The following is a description of a gene set: studied in species Mus musculus Genes predicted to be targets of miRBase v22 microRNA mmu_miR_6967_3p in miRDB v6.0 with MirTarget v4 prediction scores > 80 (high confidence targets). from publication Chen Y, Wang X (PMID 31504780) Mouse Gene Set: MIR_6967_3P, and this is the list of marker genes: Prr3, Hycc2, Ythdc2, Slc35a2, Tbc1d23, Cebpb, Slc39a1, Tstd2, Nsmce4a, Mtx3, Fgfr1op2, Ccng2, Rras2, Gngt1, Ablim3, Vmn1r32, St3gal6, Fmnl1, Arsj, Rhbdf2, Afap1l1, Bend3, Mga, Fgd2, Ergic2, Tsr2, Cldn12, Marf1, Nprl3, Rbm4, Taf7, Mia2, Gtf2a1, Glrx, Glrx2, Trps1, Cd300a, B3galnt2, Atad2b, Qpct, Strn3, Sall4, Mpig6b, Psd2, Rpl27a, Ppp2r2a, Awat1, Satb1, Isg15, Fam118a, Prtg, Cbx6, Trabd2b, Dennd2d, Zcchc10 (NCBI Gene Id 67966), Rhox6, Rimoc1, Pigv, Sycp3, Zbtb41, Fundc1, Abtb3, Hopx, Rnf2, Klhl2, Mtch2, Snai2, Klri2, Ndfip2, Dgkk, Ifi44, Slc39a8, Ak8, Usp45, Gen1, Zfp36l1, Golga1, Larp4, Dab1, Tapt1, Ptgr3 (NCBI Gene Id 225791), Alg5, Slc25a39, Itga8, Crtap, Peli1, AA986860, Ddx3x, Klhl23, Sntb2, Sp4, Syce1l, Cfhr4, Arl5a, Pappa, Tmem41a, Hsd17b12, Ube2k, Cdc73, Ppp1r17, Gbe1, Fam149a, Mapk8, Ppat, Galk2, Lsm11 (NCBI Gene Id 72290), Fez2, Larp1, Tnfaip8, Hectd1, Tmem185b, Zfy1, Rcor3, Man1a2, Ppp3r1, Gpr85, Rbm3, Nxph1, Rap1gds1, Mmut (NCBI Gene Id 319389), Rhox9, Dnmt3b, Cdkn1b, Spdye4a, Asb5, Lamp3, Ovol1, Rbm27, Fgf11, Atg5 (autophagy related 5), Sertad2, Atp5mc3, Etv5, Nhs, Pias3, Cbfa2t2, Esrp2, Celf4, Nedd4, Actrt2, Lrrtm2, Ascl2, Dpy19l2 (dpy-19 like 2), Srsf6, Naa30 (NCBI Gene Id 75009), Ppp4r2, Prkar1a, Kpna1, Crebrf, Arel1, Sipa1l1, Otud7b (OTU domain containing 7B), Calr3, Zfp37, Proser1, Sh3rf3, Avl9, Onecut2, Ctxn3, Mesp1 (mesoderm posterior 1), Phf20l1, Zfp518a, 1700025G04Rik, Tbc1d4, Tmem117, Nab1, Mrc1, Pgk1, Stx7, Gabra1, Myo1g, Spata17, Camkk2, Hsdl2, Fmr1, Pou4f1, Tnrc6c, Rsbn1, Ddx6, Gpr161, Ing5, Ralgapa1, Grm1, Ndufaf1, Gprc5a, Ica1l, Prr14l, Dab2, Lamc1 (NCBI Gene Id 226519), Ppp4r4, Vgll3, Hs6st2, Trim66, Daam1, Ssbp2, Cdc42se1, Plppr5, Pcmtd1, Lnpk, Trak2, Rab6a, Sesn1, Wdr33, Pak2, Commd2, Zmynd11 (zinc finger, MYND domain containing 11), Kif3c, Tm9sf3, Fut9, Gm21992, Dhx15, Fahd1, Cdca7l, Erbb2, Slk, Senp8, Dck, Ddx4, Slc45a4, Foxo1, Zfp780b, Svep1, Med20, Clpx (caseinolytic mitochondrial matrix peptidase chaperone subunit), Sema3a, Osbpl6, Pcdh19, Sh3gl2, Runx1t1 (RUNX1 translocation partner 1), Hnrnpm, Lum, Fut4, Sema5b (NCBI Gene Id 20357), Gins2, Eea1, Map3k3, Mtf2, Dcaf6, Eeig2, Gale, Polr3b, Kctd4, Mbtd1, Rabgap1l, Hnf4g, Sln, Hectd2, Ube3c, Elac1, Hpgds, Hoxb6, Itga6, Zfp367, Apom, Ell2, Prdm1, Gab2, Rps23rg1, Zbtb37, Gm17455, Nedd4l, Tmem26, Sema3e, Tescl, Armc8, Fubp3, Nav1